Given this list of marker genes SORL1, AKT1, PIK3CG, ALK, ADRA2A, ADORA1, APOC1, APOA2, ACACB, CRTC3, ETFBKMT, PLIN5, HCAR1, HCAR2, FMC1, GPLD1, INS, TNF, MFSD2A, CIDEA, PDE3B, IL1B, CIDEC, APOC3, PRKAA1, BSCL2, ENDOU, here is a description of the gene set: Human Gene Set: GOBP_NEGATIVE_REGULATION_OF_LIPID_CATABOLIC_PROCESS species: Homo sapiens Any process that stops, prevents, or reduces the frequency, rate or extent of the chemical reactions and pathways resulting in the breakdown of lipids.